The following is a description of a gene set: Immunological states where the immune system produces harmful responses upon reexposure to sensitizing antigens. Immunologic hypersensitivity Human Gene Set: HP_IMMUNOLOGIC_HYPERSENSITIVITY studied in species Homo sapiens, and this is the list of marker genes: IFT172, ARSL, MUC7, PTGER2, CFTR, BBS12, PTCH1, VPS51, CDSN, FOXP1, LIFR, CEP19, FOXH1, UBAP2L, TLR4, TBX21 (NCBI Gene Id 30009), SLC27A4, EDNRA, GNB2, MKKS, PEX5, SLC11A1, FLG, SIK3, SCAPER, SLC9A3, CBL, GLI2, IGHG2, POLD3, POU2AF1, CREBBP, SOX6, PEPD, IFT27, FOXP2, ERAP1, TGM5, WDR11, GPR35, IL12RB1, KLRC4, USP7, SLC19A1 (solute carrier family 19 member 1), TCF4, SOCS1, KCNN4, DSG1, MLXIPL, FOCAD, LZTFL1, TTC8, ASXL1, IPO8, CRELD1, C4B, EP300, IGKC, JAK1, IL10, RBM8A, TBK1, SEC24C, BBIP1, SIX3, WAC, DISP1, RELB, TRAIP, AGR2, TALDO1, BBS10, BBS4, SDCCAG8, DDX41, PLAG1, CEP290, UBAC2, BBS9, CDC42BPB, IDS, ARVCF, DPP9 (dipeptidyl peptidase 9), HLA-B, CTLA4, IGF2, LRBA, CFAP418, GAS1, FOXP3, TGIF1 (TGFB induced factor homeobox 1), TGFB1, LYN, IL13, HMGA2, BCL11B, HFE, WDPCP, DNASE1L3, STAT3, FGF8, SHH, BICRA, MIF (macrophage migration inhibitory factor), CCL11, STAT6, SEMA4D, GRHL2, HLA-G, IVNS1ABP, CHD1, SPIB, SUFU, CASP8, IL12A-AS1, MTOR, IL23R, MEFV, C4A, COMT, ODC1, ABCC9, IFT74, NODAL (NCBI Gene Id 8114), ALMS1, HMOX1 (heme oxygenase 1), STAT5B, HNMT, CARD10 (caspase recruitment domain family member 10), RREB1, KIT, ZNF699, GGT1, IRF5, NSUN2, ADA, ODAD3, ALOX5, PSTPIP1, TNFSF15, HLA-DQB1, SDHD, CDH3, CEACAM6, CPN1, SCLT1, TNPO3, ALG9, STAT4, UFD1 (NCBI Gene Id 7353), MKS1, HLA-DQA1, BBS1, ZIC2, CAMK2B, SRCAP, HLA-DPB1, STX1A, MST1, MED12, GP9, IL12A, JMJD1C, ELN, LMX1B, CLCA4, SMAD2, SPTBN1, COX4I2, NOD2, TBCK, DCTN4, ERI1, SCGB3A2, SLC26A9, NFKB2, NPHP1, IL6ST, CCDC28B, SLC6A14, DLL1, CSTA, CARD11, FCGR2A, HIRA, NEK9, LIG4 (NCBI Gene Id 3981), FAS, BBS5, UNC45A, STXBP1 (syntaxin binding protein 1), SRSF2, CDKN1C, KRT74, TNF, FGFR1, TRIM32, CCR1, BBS2, NKX2-1, SERPINA1, SCN4A, SPINK5, TET2, FBXO11, RFX7, TBC1D7, MIA3, ERCC2, GNB1, GCLC, PLCG2, ELOVL4, RIC1, PGM3, ARL6, IFNGR1, CARMIL2, AIRE, DOCK8, RUNX1, ARPC5, GP1BA, TBX1, CRIPTO, MMEL1, IFT56, GSTM3, AFF4, CEACAM3, BBS7, SATB2, GP1BB, CDON